The following is a description of a gene set: Any process that modulates the frequency, rate or extent of cell communication by electrical coupling involved in cardiac conduction. Mouse Gene Set: GOBP_REGULATION_OF_CELL_COMMUNICATION_BY_ELECTRICAL_COUPLING_INVOLVED_IN_CARDIAC_CONDUCTION species: Mus musculus, and this is the list of marker genes: Gjd3, Cav1, Pde4d, Sri, Irx3, Hrc